Given this list of marker genes SGCB, IFNG, ADORA2A, CX3CL1, RRAS2, IFITM3, RCN1, SLC15A3, THYN1, NUDT5, PARP12, BST2, NFKBIA, SPSB1, TMEM140, IER3, PGS1, CXCL2, PSTPIP2, PSME1, THUMPD1, CDKN1A, SFXN1, UBR4, UTP20, PPA1, TAPBP, LOX, HILPDA (NCBI Gene Id 92496), DDX18, CD70, EBNA1BP2, GADD45B, PLK2, ALDH1A2, COL4A1, AOAH, C11orf96, GBP2, CD14, IARS1, NARS1 (asparaginyl-tRNA synthetase 1), PRPF31, ZBP1 (Z-DNA binding protein 1), CCL4, CCL2, TOR1AIP2, CXCL11, CXCL3, EDN1, PDCD1LG2, KCNE4, FOS, TARS1, SERPINE1, CH25H, AGRN, WDFY1, IL12RB1, TNIP2, IRF7, CWC15, SAA1 (serum amyloid A1), CEMIP2, SLCO3A1, TIMP1, NEPRO, MAFF, PPP1R7, TRAF1, DLL4, PRMT3, CSF3, TAP1, TRAFD1, BCL2A1, CCL13, COX18, MVP, OASL (NCBI Gene Id 8638), RMDN3, CXCL9, NAA20, PNP, VDR, BATF3, IL12RB2, CCRL2, CHMP4B, SCT, IFRD1, NNMT, LGALS3BP, AEBP2, QTRT2, PSME2, NSUN4, GADD45G, XPOT, ICAM1, NOP14, OMD (osteomodulin), ATF3, CFLAR, DDIT3, LAP3, LTV1, EBI3, TNFAIP3, MARCO, ABCC1, MX1, PTGES, HBEGF (heparin binding EGF like growth factor), SOCS3, HTT, OSTC, GPR84 (G protein-coupled receptor 84), IL2RA, INO80, INHBB, TNFAIP2, CCL5, PARL, TNFSF10, IL10, LIF, FJX1, RIPK2, SOS1 (NCBI Gene Id 7838), CXCL10, GZMA, CACNB3, BATF2, OAS1, IRF1, TMEM209 (transmembrane protein 209), NFIL3, TOR1AIP1, TSPO, PSAT1, FLNB, TPST1, MOV10, CCL7, PEX11A (NCBI Gene Id 95687), SOCS2, GZMB, DHX58, NFKBIZ, TNFRSF4, RTP4, CD40, CFB, UPP1, MMP14, CHST11, STRA6, XDH, GLIPR2, IL15RA, IL15, TXNRD1, LITAF, MMP13, F11R, TRUB2, TNF, OAF, SOCS1, CTPS1, ACOD1, NUFIP1, UBE2L3, CLIC4, ASTE1, LIPG, TOR3A, LSG1, CA13, OGFR, KARS1, PLAT, FABP2, PWP1, CZIB, WARS1, MT1E, TMEM106A, MAPK6, RABL3, ZC3H12A, SELP, SYTL3, ZBTB25, RHOU, ELP1, IL1RN, GNB4, SDHAF1, here is a description of the gene set: Th17 cells are enriched by sorting FR4-CD4+ T cells from SKG mice. A large number of Th17 cells also develop spontaneously when CD4+ T cells from IFN-g-deficient (IFN-g-/-) BALB/c mice are transferred to T cell-deficient RAG2-deficient (RAG2-/-) mice and subjected to homeostatic proliferation, whereas they fail to develop in similar transfer of IL-6-deficient (IL-6-/-) CD4+ T cells to IL-6-/- RAG2-/- mice. To explore the functional molecules specifically expressed by Th17 cells, we conducted Gene Microarray analysis between 10-month-old SKG FR4-CD4+ cells and age-matched BALB/c FR4-CD4+ cells, and between IFN-g-/- CD4+ cells transferred to RAG2-/- mice and IL-6-/- CD4+ T cells transferred to IL-6-/- RAG2-/- mice. The analysis revealed that 1,556 and genes were up-regulated in 10-month-old SKG FR4-CD4+ and IFN-g-/- CD4+ T cells after homeostatic proliferation, respectively, with genes shared by the two groups of genes. The genes included those encoding cytokines, chemokines, and their receptors, such as IL-1 receptor type1 (IL-1R1), IL-17, IL-22, IL-21, CCR6, and CCL20. from publication Hirota K, Yoshitomi H, Hashimoto M, Maeda S, Teradaira S, Sugimoto N, Yamaguchi T, Nomura T, Ito H, Nakamura T, Sakaguchi N, Sakaguchi S (PMID 18025126) Human Gene Set: GSE9316_IL6_KO_VS_IFNG_KO_INVIVO_EXPANDED_CD4_TCELL_DN studied in species Homo sapiens Genes down-regulated in CD4 T cells with in vivo expansion: IL6 versus IFNG.